The following is a description of a gene set: species: Mus musculus The process of covalently altering one or more amino acids in a protein after the protein has been completely translated and released from the ribosome. Mouse Gene Set: GOBP_POST_TRANSLATIONAL_PROTEIN_MODIFICATION, and this is the list of marker genes: Mkrn1, Mtbp, Fbxo31, Rnf130, Hspa1b, Egr1, Uchl4, Prickle1, Uba6, Plk1, Klhl7, Otub2, Uchl1, Ube2i, Flcn, Uba1, Cul5, Znrf1, Hlcs, Pja2, Tspo, Zmiz2, Trim69, Ube2z, Hectd1, Ndfip1 (Nedd4 family interacting protein 1), Trip12, Kbtbd13, Pten, Ube2frt, Rnf144a, Usp17lc, Arrb2 (arrestin, beta 2), Parp12, Rab40b, Wdr24, Usp21, Brcc3, Socs5, Zfp598, Nod2, Rnf168, Trpc4ap, Asb14, Fbxl21, Fbxo7, Ctu2, Fbxw8, Sh3rf2, Ube2v2, Cdc16, Cdc34, Rnf114, Neurl3, Rnf111, Lrrk2, Usp32, Kbtbd7, Ube2w, Sumo2, Trib2, Med30, Rnf166, Rab40c, Det1, Lcmt1, Dcun1d3, Hectd2, Trim56, Marchf1, Bcl11a, Rwdd3, Derl1, Ube2f, Cul3, Kctd11, Cul4b, Spsb1, Kctd9, Cnot4, Trim41, Asb3, Kcmf1, Trim30c, P3h1, Agbl1, Anapc15, Ltn1, Mtor, Nop53, Mapk15, Arrdc1, Esco2, Prmt3, Rnf6, Dcaf5, Rpl23, Trim25, Dcaf11, Cav1, Ube2a (NCBI Gene Id 56394), Asb2, Macroh2a1, Appbp2, Cbll1, Pef1, Cry1, Rnf167, Med1, Cops7a, Rnf227, Dtx3 (NCBI Gene Id 80904), Cbfb, Agbl4, Usp5, Dcaf1, Rps2, Obi1, Rnf133, Rc3h1, Cul2, Aimp2, Usp29, Trpm4, Cblb (Casitas B-lineage lymphoma b), Tollip, Fscb, Pttg1ip, Rnf14, Usp37, Eipr1, Gm11690, Toporsl, Dtx2, Med10, Bex1, Nqo1 (NAD(P)H dehydrogenase, quinone 1), Megf8, Prkce, Ube2j2, Ubox5, Fbxo10 (F-box protein 10), Tradd, Herc6, Stx1a, Fancm, Parp11, Commd1, Klhl12, Rnf212, Aurkb, Enpp1, Anapc7, Vps18, Senp6, Tspyl5 (NCBI Gene Id 239364), Phf23, Ube2g1, Atg5, Arnt (NCBI Gene Id 51910), Cand1, Usp43, Rnf122, Otud6b, Trim7, Ube3a, Ctnnb1, Rnf19b, Trim21, Trim26, Prkcb, Rnf38, Cdc20, Cdk5rap3, Neurl1b, Usp38, Sash1, Hmg20a, Os9, Ddrgk1, Hint1, Stambpl1, Rnf43, Mindy4, Trim44, Med23, Rnf146, Ambra1, Cops6, Ift80, Ube2d4 (ubiquitin-conjugating enzyme E2D 4), Senp3, Sirt1, Med31, Anapc10, Ppara, Spata2, Cdc34b, Abl1, Ubr1, Usp20, Marchf6, Mkrn2, Skp2, Tnf, Usp19, Tsg101 (NCBI Gene Id 22088), Rnf185, Bfar, Huwe1, Cops3, Fbxo30, Lrrc41, Socs6, Wwp1, Desi1, Socs7, Klhl3, Ube2k, Rnf208, Usp48, Rnf25, Jak2, Dda1, Trim23, Mad2l2, Ube3b, Ubr5, Fem1b, Ddx3x, Kctd10, Rnf144b, Prkcd, Lcmt2, Asb1, Tpst1, Fbxo25, Nhlrc3, Asb18, Rnf138rt1, Minar1, Trim12c, Hectd3, Lonrf2, Rnft1, Anapc11, Kbtbd6, Trim34b, Trim35, Brca1, Parp1, Rnf125, Bex2, Rffl, Dcaf12, Traf2, Fancf, Fbxo9, Gabarap, Usp25, Rpl11, Sumo3, Usp17lb, Rnf44, Klhl42, Sumf1, Rnf181, Med24, Rela, Cyld, Wsb2, Rnf186, Rnf220, Rps6ka4, Asb17, Med7, Skp1 (NCBI Gene Id 76591), Ube2n, Uba52, Bap1, Asb11, Ccnc, Wdr77, Ddb2, Aktip, Dzip3, Kdf1, Fbxo43, Rad18, Agbl5, Wdtc1, Ube4b, Marchf7, Fbxl12, Usp9y, Trim17, Trim33, Usp12, Frey1, Caml, E4f1, Ube2e2, Fbxl17, Large1, Usp10, Ube2srt, Ogt, Agtpbp1, Trim3, Trim30d, Bex4, Wnk1, Asb15, Spop, Znrf4, Dcun1d2, Sqstm1 (NCBI Gene Id 18412), Fbxo22, Cdkn2a, Ube2q2, Adgrb1, Socs3, Paxip1, Senp2, Znrf2, Bard1, Usp27x, Ndp, Ubac1, Mta1, Ufc1, Spsb4, Rnf26, Cdca3, Trim52, Ttl, Fbxw5, Fam107a, Vcp (valosin containing protein), Spry2, Trim31, Jade2, Pias1, Cops5, Zranb1, Mgrn1, Uba7, Hdac8, Marchf9, Rnf11, Ube2b, Asb5, Trim32 (NCBI Gene Id 69807), Tm9sf5, Gnl3, Rnf34, Dnajb2, Dcaf10, Traip, Itch, Rnf157, Ubd, Rnf115, Med17, Ifih1 (NCBI Gene Id 71586), Dcaf15, Ranbp2, Vps11, Bmi1, Ube2l6, Tnfaip1, Stt3b, Tcf25, Trim11, Keap1, Vps28, Rbx1-ps, Rnf135, Klhdc2, Mdm4, Dcaf6, Baz1b (bromodomain adjacent to zinc finger domain, 1B), Uspl1, Rnf169, Rps6ka5, Parp3, Med8 (NCBI Gene Id 80509), Uba5, Mapk9, Zswim8, Cdc23, Fbxo11, Trim71, Fau, Sphk1, Ivns1abp, Vcpip1 (valosin containing protein (p97)/p47 complex interacting protein 1), Nfe2l2, Lztr1, Tnks, Senp1, Ubr4, Map3k12, Gsk3b, Chfr, Hspbp1, Usp18 (ubiquitin specific peptidase 18), Crtap, Rnf7, Abca2, Rnf26rt, Cdc14b, Klhl18, Birc2, Rnf139, Bcl2, Shprh, Cdc26, Semp2l1, Fbxl22, Med6, Rangap1, Fbxw11, Ubqln1, Cul4a, Usp2, Ccnb1ip1, Dcun1d5 (NCBI Gene Id 76863), Rnf138, Asb12, Kdm1a, Rc3h2, Ube3c, Spsb3, Uvssa, Zc3hc1, Trim47, Rag1 (recombination activating 1), Uba3, Prkn, Mid2, Unkl, Rpgr, Med20, Birc7, Laptm5, Fbxo33, Cep63, Aurkaip1, Tbc1d7, Ube4a (NCBI Gene Id 338480), Klhl10, Hdac6, Fem1c, Ube2j1, Smad7, Mib1, Epas1, Usp13, Marchf3, Cops4 (NCBI Gene Id 52442), Rps27a, Trim24, Gclc, U2af2, Isg15, Rnf10, Cops2, Rnf216, Wwtr1, Rhbdd1, Usp17le, Cul7, Shmt2, Birc6, Btrc, Usp53, Trim62, Fbxw15, Gan, Mylip, Cdk2, Epm2a, Dcaf17, Septin4, Hsp90ab1, Lrsam1 (NCBI Gene Id 227738), Prpf19, Usp14, Dcun1d1, Wdsub1, Sprtn, Usp44, Rnf31, Rchy1, Rps3, Cand2, Ube2dnl1, Topors (NCBI Gene Id 230074), Pex10, Hace1, Fanci, Wdr48, Yod1, Trim38, Otulinl, Hsp90aa1, Ube2m, Usp16, Hecw2, Ube2h, Nae1, Asb9, Traf6, Cop1, Herc2, Fbxl5, Neurl2, Usp33, Wfs1, Spopl, Pja1, Traf7, Traf3ip2, Rnf2, Ttc3, Anapc15-ps, Anapc16, Kbtbd8, Fem1al, Usp1, Crbn, Ndfip2, Usp4, Rnf113a1, Rnf128, Trim40, Amer1, Rlim, Ctu1, Kctd21, Rnf40, Fbxo5 (NCBI Gene Id 97658), Smurf2, Trim13, Ubr3, Svbp, Tank, Marchf4, Pcnp, Bag2, Rpl5, Rnf103, Otub1 (NCBI Gene Id 107260), Nosip, Asb8, D7Ertd443e, Znrf3, Rnf182, Park7, Bcl10, Cul9 (cullin 9), Mycbp2, Fbxo3, Pnkp, Dcun1d4, Med27, Ufm1, Zfp451, Hamp2, Cdk5, Usp7, Ube2d2a, Usp11, Axin1, Arrdc3, Egfr, Parp10, Fbxo45, Psen1, Gps1 (NCBI Gene Id 209318), Zzef1, Tulp4, Irf2bpl, Atg10, Trib3, Lnx1, Klhl40, Eloc, Marchf2, Parp16, Zfp91, Rnf183 (ring finger protein 183), Wbp1l (WW domain binding protein 1 like), Ube2c, Klhdc3, Rack1, Usp22, Senp7, Cops7b, Zc4h2, Ripk2, Uba2, Asb10, Ubb, Dscc1, Klhl9, Zmiz1, Rnf41, Nsmce3, Klhl17, Gtpbp4, Rnf187, Otud4, Ube2dnl2, Brcc3dc, Marchf5, Rfwd3, Brap, Sirt7, Ccnf, Psmd14, Akt1, Usp15, Siah1a, Trim2, Tor1a, Washc1, Ppp1r11, Med18, Otud1, Anapc4, Usp17la, Chp1, Ube2d3, Trim68, Sh3rf1, Esco1, D1Pas1, Usp17ld, Ppia, Prkcg, Psmd10, Fyn, Rps7, Arih1, Trim12a, Usp24, Usp36, Gsk3a, Capn3, Wipi2, Trim55, Senp5, Usp3, Ube2q2l, Rnf4, Fbh1, Rbx1, Ahrr, Usp45, Nscme3l, Bag5, Semp2l2a, Rnf113a2, Ubxn2a, Mdm2, Ube2u, Ngf, Elob (NCBI Gene Id 98096), Hamp, Plaa, Fbxl7, Mapk8, Angpt1, Ddb1, Kbtbd2, Asb4, Mocs3, Trim39 (NCBI Gene Id 79263), Birc3, Ccna2, Senp8, Rnf180, Pinx1, Rnf121, Pabpn1l, Nxn, Msl2, Rnf223, Anapc5, Ube3d, Nedd4l, Trim45, Cbx4, Nmi, Hmg20b, Usp49, Ubr7, Fbxo38, Padi4, Pex2, Nedd8, Uhrf2, Irgm2, Parp8, Usp26, Ube2e1, Usp54, Rnf152, Klhdc10, Ube2g2, Ubc, Uchl3, Dcaf8, Trim5, Arel1, Kctd13, Bex3, Pias3, Magel2, Herc3, Fbxo32, Cd300ld3, Klhl41, Arih2, G2e3, Pex12, Rusc1, Ube2e3, Ptpn22, Trim28, Mad2l1, Sox4, Wsb1, Ube2o, Ark2c, Per2, Sae1, Tnip1, Fbxw7, Stambp, Rnf149, Cul1, Triml1, Otud3, Trim63, Rnf126, Gps2, Trim34a, Nt5c2, Mastl, Btbd35f1, Daxx, Sharpin, Josd2, Otud7a, Usp50, Rnf19a, Klhdc1, Neurl1a, Inava, Dtl, Fancl, Ube2d1, Med11 (mediator complex subunit 11), Mul1, Grb2, Peli1, Hspa5, Enc1, Med21, Irf2bp1, Dnah12, Hltf, Sirt6, Med12, Trim30a, Rnf8, Marchf11, Hif1a, Asb16 (ankyrin repeat and SOCS box-containing 16), Klhl2, Syvn1 (NCBI Gene Id 98160, synovial apoptosis inhibitor 1, synoviolin), Dcst1, Dysf, Anapc1, Egr2, Uhrf1, Pdcd6, Foxf2, Arrb1, Irgm1, Siah2, Usp46, Fgfr3, Klhl36, Dnaja1, Lrr1, Fbxo4, Trim27, Usp28, Otud5, Fbxl2, Cdc27, Vhl, Dnaja3, Nedd4, Marchf8, Ankib1, Rassf5, Pink1 (PTEN induced putative kinase 1), Asb13, Fbxo2, Rasd2, Sirt2, Wwp2, Klhl8, Ticam1, Rnf20, Anapc2, Icmt, Mib2, Nfe2l1, Trim59, Cops8, Rnf13, Btbd1, Tmem129, Dcaf13, Ube2v1 (NCBI Gene Id 66589), N4bp1, Rmnd5a, Rnf5, Ube2r2, Trim65, Prkca, Parp14, Ubxn1, Pias4 (protein inhibitor of activated STAT 4), Semp2l2b, Ubr2, Egf, Mkrn3, Pkn1, Kctd6, Rnf225, Spsb2, Pdzrn3, Nub1, Daw1, Map3k1, Usp47, Asb7, Urm1, Xiap, Usp9x, Ube2d2b, Siah1b, Trim30b (tripartite motif-containing 30B), Cops9, Psen2, Gbp4, Rnf170, Klhl20, Rnf123, Sde2, Fem1a, Rnf112, Fbxo6, Rnf141, Stt3a, Asb6, Socs4, Peli2, Trim37, Sh3rf3, Trim8, Npm1, Cbl, Rbck1, Fzr1, Klhl15, Abcb11, Cblc, Klhl25, Hecw1, Cish, Ufl1, Tnks2, Ube2q1, Uba1y, Usp51, Anapc13, Rnf7l, Herpud1, Usp42, Mindy3, Uchl5, Otud7b (NCBI Gene Id 99649), Sumo1, Trim9, Rassf1, Birc5, Amfr, Atxn3, Igtp, Tes3-ps, Usp34, Tgfbr1, Ppil2, Klhl24, Fbxl15, Usp39, Socs2, Rnf212b, Arrdc4, Nlrc3, Limk1, Peli3, Stub1, Gnl3l, Parp6, Usp30, Otud6a, Dtx1, Atg7, Cep78, Herc4, Klhl13, Parp2 (poly (ADP-ribose) polymerase family, member 2), Nsmce2, Sumf2, Ring1, Abraxas2, Nfx1 (NCBI Gene Id 93788), Socs1, Tnfrsf1a, Klhl22, Zc3h12a, Trib1, Ube2t, Hdac4, Neurod2, Ercc8 (excision repaiross-complementing rodent repair deficiency, complementation group 8), Pias2, Dtx3l, Usp8, Otulin, Tnfaip3, Atg16l1, Usp40, Trim58, Pcmtd1 (protein-L-isoaspartate (D-aspartate) O-methyltransferase domain containing 1), Ube2l3, Dtx4, Vipas39, Smurf1, Cdk8, Trim6 (tripartite motif-containing 6), Zswim2, Ube2s, Fbxl3, Atg3, Hdac3, Rnf217, Ankrd9, Klhl21, Rbbp6, Josd1, Dcaf7, Eya1, Ube2ql1, Rnf213, Ttc36, Nhlrc1, Fbxo28